The following is a description of a gene set: Induction of autophagy and toll-like receptor signaling by graphene oxide species: Homo sapiens Human Gene Set: WP_INDUCTION_OF_AUTOPHAGY_AND_TOLLLIKE_RECEPTOR_SIGNALING_BY_GRAPHENE_OXIDE, and this is the list of marker genes: TLR4, TLR9, IRF3, MAP1LC3A, TNF, IFNB1, IFNG, NFKB1, BECN1, MYD88, TRAF6